The following is a description of a gene set: Reactome Pathway: SHOC2 M1731 mutant abolishes MRAS complex function This pathway describes the effect of a loss-of-function mutation in SHOC2 on RAF activation. How both loss- and gain-of-function SHOC2 mutants can contribute to RAF pathway activation remains to be elucidated. part of: Signaling by MRAS-complex mutants studied in species Homo sapiens, and this is the list of marker genes: YWHAB, PPP1CC, ARAF, RAF1, MRAS, PPP1CB, BRAF (B-Raf proto-oncogene, serine/threonine kinase), SHOC2